The following is a description of a gene set: from publication Pello OM, De Pizzol M, Mirolo M, Soucek L, Zammataro L, Amabile A, Doni A, Nebuloni M, Swigart LB, Evan GI, Mantovani A, Locati M (PMID 22067385) Genes down-regulated in macrophages: resting differentiated versus MYC inhibited. Human Gene Set: GSE32164_RESTING_DIFFERENTIATED_VS_CMYC_INHIBITED_MACROPHAGE_DN In response to microenvironmental signals macrophages undergo different activation, indicated as classic/M1 and alternative/M2 polarization. C-Myc transcription factor could be an essential player in M2 polarization. Functional relevance of c-Myc in M2 macrophage biology is investigated by evaluating the effect of 100-58F4, on the transcriptional profile induced on human macrophages by IL-4. species: Homo sapiens, and this is the list of marker genes: BRK1, SLC39A8, FADS1, NDUFA2, STK40, TIMM23, ERCC3, SEPHS2, TUFM, ATP11A, BZW2, LDHB, PRKCSH, S100A10, PHPT1, HACD3, SFMBT2, CSNK1E, PTGER4, CAPZB, ATP6V1D, PLIN2, FRMD6, CWC15, PDCD4, BTG3 (NCBI Gene Id 10950), ENTREP3, CTLA4 (cytotoxic T-lymphocyte associated protein 4), GLRX, STX5, PKP4, SRGAP2, TBRG1 (NCBI Gene Id 84897), F2R, MKRN1, FAS, REPS1, LEPROT, DTX1, TMEM176A, SIT1, NABP1, MFHAS1, CD3G, OTULINL, FLT3LG, STX6, TRIR, TRAF1, EIF4A3, MRPL44, TCF7, HRAS, KLF3, PSME1, CCR2, MRPL35, ARHGAP9, PPP5C, PRDM1, ITM2C, HPN, NANS, MACROH2A1, BAG1, RECK, DOK2, ITM2A, MYO6, FASLG, SPTSSA, IFIH1, IL18R1, HTATIP2, FYN, METTL9, TENT5C, ZSCAN12, GZMA, ID2, FN1, NCBP1, NPC2, MICOS10, GPR65, PFKP, CD82, TSPYL4, CCR5, LCK (NCBI Gene Id 95387), STIM1, PRKACB, CNDP2, FLOT1, SUPT4H1, ELOVL6, RAC2, CXCL10, CD96, PRF1, CD27, SLC33A1, WAS, HM13, PRDX6, IFI27, CBX6, GPC1, FDX1, ICAM1, CD44, KLRG1, CSF1R (NCBI Gene Id 8156), S100A6, YIPF3, CKB, BRAP, ALDOA (NCBI Gene Id 226), RRP7A, RPL19, THRA, ABHD8, FIP1L1, PIM1, NUP50, SULF2, SH2D2A, CD6, PIP5K1A, PSMB8, KLHL9, AAMP, CISH, BUB3, CORO1B, TNFRSF18, NRP1, PPP4C, IFIT3, CCL5, CSNK1G2, PTTG1, VMP1, CD5, TUBGCP4, DUSP11, PSMB3, GATA3, IFIT2, TMCO1, TMEM9B, DYNLL2, ENO1, MED10, EBP, DNAJC15, TMEM176B, BATF, CTSV, ITGB1, HPCAL1, AGFG1, ZFPM1, UCK2, RASSF5, JCHAIN, DNAJC1, DAD1, NUDT16L1, DDHD2, SOAT2, NMI, SPNS1, CD247, SNX14, IL18RAP, SLIRP, MTHFD2, CTSD, RGS3, GALNT10, PDCD6, B4GALNT1, PIH1D1, KLRD1 (NCBI Gene Id 92677), NBEAL2, LRWD1, ASRGL1, CAMK2B, GSTK1, SLC38A10, RPS6KA4, NOTCH1, TES, CDK2AP2, PRPF8, COPG1, S100A4, HOPX, MYD88 (NCBI Gene Id 4615)